The following is a description of a gene set: Decreased number of peripheral myelinated nerve fibers Human Gene Set: HP_DECREASED_NUMBER_OF_PERIPHERAL_MYELINATED_NERVE_FIBERS studied in species Homo sapiens A loss of myelinated nerve fibers in the peripheral nervous system (in general, this finding can be observed on nerve biopsy)., and this is the list of marker genes: PMP22, DNMT1, PRX, KIF1B, WNK1, FGD4 (FYVE, RhoGEF and PH domain containing 4), DHH, SH3TC2, APTX, RETREG1, TYMP, LIG3, MME (membrane metalloendopeptidase), POLG, FLRT1, GDAP1, MTRFR, PNPT1, HK1, SBF2, NEFL, EGR2, RAB7A, LMNA (NCBI Gene Id 7816), MFN2, VPS13A, JPH1, TWNK, HSPB8, PLEKHG5, KIF1A, NGF, NTRK1, VRK1, RAI1, GAN, RRM2B, DNM2, TFG (NCBI Gene Id 50989), TDP1, KLC2, GJB1, MPZ, SPTLC1, SPG11, ELP1, SACS, MPV17, TRIM2, SCN9A